The following is a description of a gene set: Human Gene Set: MIR222_3P studied in species Homo sapiens Genes predicted to be targets of miRBase v22 microRNA hsa-miR-222-3p in miRDB v6.0 with MirTarget v4 prediction scores > 80 (high confidence targets). from publication Chen Y, Wang X (PMID 31504780), and this is the list of marker genes: NAA25, WDR47, DNAJC6, FNDC3A, FMR1, GABRG1, PCMTD1, CDKN1B, RBP2, ZNG1F, MARF1, FOXN2, ATXN1, HIPK1, GPBP1, HMBOX1, FERMT2, HNRNPH3, SBK1, LHFPL2, CASZ1, ANKRD12, FNIP2, CDK19, PPP3R1, ZMYM2, TSC22D3, PIEZO2, PLXNC1, RFX3, ERBB4, TUB, PHACTR4, C6, GNAI3, ZFYVE16, RAB18, SYBU, USP27X, GRIK1, KIT, IRX5, GALNT3, SEC62, ZNF615, BEAN1, ZNG1E, CCDC18, ADAM22, MIA3, SNRNP48 (small nuclear ribonucleoprotein U11/U12 subunit 48), DCUN1D1, TCF12 (transcription factor 12), VAPB, SEMA3C, RAB1A, RFX8, L3MBTL1, CTDSPL2, ATOSA, SVIP (small VCP interacting protein), ZFPM2, SYNCRIP, AKAP5, INA, ZNG1B (Zn regulated GTPase metalloprotein activator 1B), LUZP2, CLRN1, MIER3, SNX4, SMARCA5, PAIP1, TUBA1A, BRWD1, PGPEP1L, NRK, ESR1, POGZ, RDX, ETV3, DCAF12, BBC3, ASPA, FGF14, RGS6, RIT2, PIK3R1, ZNG1C, SESN3, SNAP29, GRB10, RNPS1, RNF4, EIF5A2, LBR, AP3B2, ATP1B1, WDR35, GDF9, C3orf70, NIPAL4 (NIPA like domain containing 4), MYLIP, TSPAN13, CLGN, KDR, TP53BP2, SLC4A7, DPH6, ZNF91, BEND4, ZNG1A, EIF3J, ARHGEF38, PAF1, DMRT3 (NCBI Gene Id 63949), MIDN, ZFP36L2, WNK3, HECTD2 (HECT domain E3 ubiquitin protein ligase 2), RIMS3, AGTPBP1, PLCL2, TMCC1, TDRP, ARF4, IRF2, LYPLA1, NXPH1, ZNF385A, NYAP2, CXCL12, TGS1, KLF7, GABRA1, AIDA, MRAP2, DENND1B, SHLD2, CHSY1, DPP8, NAP1L5, VASH1, BCL2L11, PPP2R2A, MARK1, SLC2A13, PANK3, C6orf118, RSBN1L, PRRC2B, CDH2, KIF16B, RFX7, EML6, FXN, BICDL1, ZNF181, UBE2J1, TLE3, SYT10, SANBR, TFG, DDIT4, CCN1, POLR3E, GUCY1A2, TRPC3, TNRC6C, BRWD3, SUN2, CASR, APOLD1 (NCBI Gene Id 81575), CLVS2, AQP3, KIF20A